The following is a description of a gene set: Human Gene Set: GSE18791_CTRL_VS_NEWCASTLE_VIRUS_DC_16H_DN from publication Zaslavsky E, Hershberg U, Seto J, Pham AM, Marquez S, Duke JL, Wetmur JG, Tenoever BR, Sealfon SC, Kleinstein SH (PMID 20164420) The dendritic cell (DC) is a master regulator of immune responses. Pathogenic viruses subvert normal immune function in DCs through the expression of immune antagonists. Understanding how these antagonists interact with the host immune system requires knowledge of the underlying genetic regulatory network that operates during an uninhibited antiviral response. In order to isolate and identify this network, we studied DCs infected with Newcastle Disease Virus (NDV), which is able to stimulate innate immunity and DC maturation through activation of RIG-I signaling, but lacks the ability to evade the human interferon response. To analyze this experimental model, we developed a new approach integrating genome-wide expression kinetics and time-dependent promoter analysis. We found that the genetic program underlying the antiviral cell state transition during the first 18-hours post-infection could be explained by a single regulatory network. Gene expression changes were driven by a step-wise multi-factor cascading control mechanism, where the specific transcription factors controlling expression changed over time. Within this network, most individual genes are regulated by multiple factors, indicating robustness against virus-encoded immune evasion genes. In addition to effectively recapitulating current biological knowledge, we predicted, and validated experimentally, antiviral roles for several novel transcription factors. More generally, our results show how a genetic program can be temporally controlled through a single regulatory network to achieve the large-scale genetic reprogramming characteristic of cell state transitions. Genes down-regulated in comparison of control conventional dendritic cells (cDC) at 0 h versus cDCs infected with Newcastle disease virus (NDV) at 16 h. species: Homo sapiens, and this is the list of marker genes: RIPOR2, FEM1C, TRANK1, RYBP, CD38, SLFN5, ADCY10, ZBTB5, CARINH, EXT1, IFNL2, MVB12A, FGFBP3, HCG4B, HS3ST3B1, THAP3, XAF1 (NCBI Gene Id 54739), PAG1, RPS6KA5, CASP10, FAM107B, GALNT3, GBP5, ZNF267, USP11, TMEM39A (NCBI Gene Id 55254), IL11, EIF2AK3, SGPP2, SBK1, RARG, GAS1, COL27A1, PDE4B, AMOTL2, RIGI, ZC3H12C, DUSP16, CMPK2, TRIM25, PLSCR2, CNKSR3, TRPM4, BMP3, ZNF367, HERC5, MDK, PIGA, DDX60, FAM135A, DBF4B, WARS1, KDM6B, SERPING1, SIGLEC1, TMCC3, TPSD1, MASTL, ST7-AS1, TNF, HPSE, NEURL3, STK19, NFIX, BBC3, LTA, CCDC9 (coiled-coil domain containing 9), PTGS2, FOXO3, IFIT1, PTK2B (protein tyrosine kinase 2 beta), PLA1A, MLLT3, ARAP2, CACNA1A, TOMM34, MARCKSL1, PAPOLG, DNAH10, UCA1, GLCCI1, APOL6, GCH1, DUSP5, HIVEP2, FLJ13224, SHFL, IL18RAP, SDCBP2, HERC6, MIR155HG, DND1, SULT4A1, SARDH, SLAMF7 (NCBI Gene Id 57823), CREB5, ARID5A (AT-rich interaction domain 5A), GHRL, MAML2, PPM1K, TRAF1, ABTB2, FBXL6, SFRP5, HILPDA, BATF2, NOS3, OASL, NEMP1, IL15RA, RIPK2, CSRNP1, DHX58, ZHX2, NCF1C, DHDH, SLC25A28, TENT4A, FAS, NLRC5 (NCBI Gene Id 84166), IFIT3, SP140, RTP4, HOXD10, TNFSF15, ERN1 (endoplasmic reticulum to nucleus signaling 1), AZIN2, SLC1A6, IRAK2, ARHGEF11, HTRA3, ADAR, SELENOI, HELZ2, BEND5, IFIT2, LAMP3 (lysosomal associated membrane protein 3), IDO1, RLF, RICTOR, ZSCAN12, NEXN, PNPT1, OAS2, SLC9B1, DLGAP1-AS1, IGHM, STAT2, NAT8B, ASH1L-AS1 (ASH1L antisense RNA 1), IFIT5, IRF7, PARP14, IFI6, GTPBP2, C21orf91, SOD2, NMRAL2P, PMAIP1, HCN3, CDX2, EBI3, CABP1, LIPE, HTR3B, IFNA8, PELI1, SAMD9, IFI44, PFKFB3 (6-phosphofructo-2-kinase/fructose-2,6-biphosphatase 3), C17orf67, NPC1L1 (NPC1 like intracellular cholesterol transporter 1), PHF11, SPATA18, EPSTI1, MX2, GBP4, MXD1, ATOH1, ARL5B, OTUD1, KCNQ1DN, IRF1, FLJ38576, OAS3, MMP11, PGAP1, IRF8, ISG15, HMGN2P46, FJX1, PLSCR1, ITIH4, CXCL9, LINC00608